Given this list of marker genes IFIT1P1, ATP8A2P2, SERTM1, RNU6-71P, RN7SKP1, LINC00571, NBEA, LINC00445, LINC00437, FRY-AS1, RFXAP, RNA5SP26, SMAD9-IT1, ENSG00000273507, RFC3, ALG5, RXFP2, ENSG00000308044, STARD13-AS, NDE1P2, CCNA1, ANKRD26P2 (ankyrin repeat domain 26 pseudogene 2), RNU6-56P, PLA2G12AP2, LINC02344, DCLK1, LINC02334, CCDC169-SOHLH2, SPART-AS1, ZAR1L, EXOSC8, TRPC4, N4BP2L2-IT2, LINC00457, VDAC1P12, KL, EIF4A1P5, PDS5B, SCAND3P1, LINC00547, ENSG00000308211, LINC02343, POSTN, ENSG00000212293, RPS12P24, H2ACP1, SPART, ARL2BPP3, UFM1, NHLRC3, SOHLH2, N4BP2L2, ENSG00000289381, TOMM22P3, STOML3, LINC00366 (NCBI Gene Id 100874147), ENSG00000199196, TCEAL4P1, N4BP2L1, GAMTP2, CSNK1A1L, PROSER1, SMAD9, FRY, PHB1P13, EEF1DP3, LINC00423, GAPDHP34, RPL29P28, FREM2-AS1, RNU5A-4P, BRCA2, SUPT20H, LAMTOR3P1, LINC01048 (long intergenic non-protein coding RNA 1048), PRDX3P3, CCDC169, STARD13, FREM2, NXT1P1, MAB21L1, STARD13-IT1, RNY1P4, HSPD1P9, here is a description of the gene set: studied in species Homo sapiens Human Gene Set: chr13q13